Given this list of marker genes GRIA1, KCNN2, CEP152, PDGFB, EMC10, PTCHD1, GATAD2B (GATA zinc finger domain containing 2B), PANK2, BCR, KMT5B, MAPK1, POGZ, HNRNPC, ZBTB20, CHD8, HDC, SLITRK1, COASY, SLITRK2, SPTBN1, CRKL, VPS13A, ACBD6, ARID2, PUF60, ZSWIM6, GNB1, here is a description of the gene set: Repeated, individually recognizable, intermittent movements or movement fragments that are almost always briefly suppressible and are usually associated with awareness of an urge to perform the movement. species: Homo sapiens Tics Human Gene Set: HP_TICS